Given this list of marker genes Atp1a4, Cep290, Tmem237, Rho (rhodopsin), Spata7, Cnga1, Rd3, Gucy2f, here is a description of the gene set: Mouse Gene Set: GOCC_ROD_PHOTORECEPTOR_OUTER_SEGMENT The outer segment of a vertebrate rod photoreceptor that contains sealed membrane discs that are not connected to the ciliary membrane and containing rhodopsin photoreceptor proteins. species: Mus musculus